The following is a description of a gene set: Genes selectively expressed by cells fated to differentiate as callosal projection neurons in embryonic day 14.5 mouse cortex. studied in species Mus musculus Mouse Gene Set: HEVNER_CORTEX_COMMITTED_TO_CALLOSAL_PROJECTION_NEURON_FATE from publication Bedogni F, Hevner RF (PMID 34321999), and this is the list of marker genes: Ttc28, Lratd1, Ppp2r1b, Lhx2, Dusp14, Lpl, Hs3st1, Robo2, Ptprd, Hs6st2, Ndrg1, Limch1, Satb2, Dpy19l1, AI504432, Palmd (NCBI Gene Id 66688), Ntng2, Plxna4, Bcl6, Cntn2, Epha3